Given this list of marker genes CYP27A1 (cytochrome P450 family 27 subfamily A member 1), OSBP, OSBPL9, SLC27A2, AMACR, OSBPL6, STARD5, SLC27A5 (NCBI Gene Id 22942), CH25H, SLC51A, NCOA1, SLC10A1, AKR1D1, AKR1C4, SLC10A2, RXRA (retinoid X receptor alpha), ALB, AKR1C2, SCP2, SLCO1A2, OSBPL1A, SLC51B (NCBI Gene Id 123264), NCOA2, BAAT, CYP7A1, FABP6, ACOT8, SLCO1B1, OSBPL3, ABCC3, OSBPL7 (NCBI Gene Id 54871), ABCB11, SLCO1B3, ACOX2, AKR1C3, CYP39A1, HSD3B7, OSBPL2, AKR1C1, CYP8B1, CYP46A1, HSD17B4, NR1H4, CYP7B1, here is a description of the gene set: part of: Metabolism of steroids species: Homo sapiens Reactome Pathway: Bile acid and bile salt metabolism In a healthy adult human, about 500 mg of cholesterol is converted to bile salts daily. Newly synthesized bile salts are secreted into the bile and released into the small intestine where they emulsify dietary fats. About 95% of the bile salts in the intestine are recovered and returned to the liver. The major pathway for bile salt synthesis in the liver begins with the conversion of cholesterol to 7alpha-hydroxycholesterol. Bile salt synthesis can also begin with the synthesis of an oxysterol - 24-hydroxycholesterol or 27-hydroxycholesterol. In the body, the initial steps of these two pathways occur in extrahepatic tissues, generating intermediates that are transported to the liver and converted to bile salts via the 7alpha-hydroxycholesterol pathway. These extrahepatic pathways contribute little to the total synthesis of bile salts, but are thought to play important roles in extrahepatic cholesterol homeostasis.